The following is a description of a gene set: Human Gene Set: GOCC_CYCLIN_DEPENDENT_PROTEIN_KINASE_HOLOENZYME_COMPLEX Cyclin-dependent protein kinases (CDKs) are enzyme complexes that contain a kinase catalytic subunit associated with a regulatory cyclin partner. species: Homo sapiens, and this is the list of marker genes: CCNI, CCNI2, CCNJL, CDK3, GTF2H1, MNAT1, GTF2H2C_2, CCNE2, CCNB1, GTF2H4, CDKN2D, BCCIP, CCNY, MED12, CCNA1, CCNT2, CCNF, CKS2, SNW1, CCNK, PCNA, CCNO, CCNB2, RB1, CDKN1A, CCNP, CDK6, CKS1B, GTF2H2C, ERCC3, CDK11A, CDK8, GTF2H5, CCNL1, CCNT1, CDK13, CDK19, CCNA2, CDK14, CDK10, GTF2H2, CCNC, MED13, CDK16, CCNB3, CDK2, CDK4, CDK5R2, CNPPD1, CCNJ (NCBI Gene Id 54619), CCND3, CCND2 (NCBI Gene Id 894), CDK12 (cyclin dependent kinase 12), CDK9, CCNH, GTF2H3, CCNL2, CDK11B, CCNG2 (cyclin G2), CCNE1, CDK5R1, CDK5, CDK1, CCNQ, CDK7, CCNG1, MMS19, ERCC2, CCND1